Given this list of marker genes TNFSF14, EHD1, EHD2, FLOT1, NFATC2, IL4R, CAPN2, GDF15, CD53, CCL8, CXCL9, ADGRB1, MYOD1, RIPOR2, SCGB3A1 (NCBI Gene Id 92304), MAPK14, here is a description of the gene set: Any process that activates or increases the frequency, rate or extent of myoblast fusion. Human Gene Set: GOBP_POSITIVE_REGULATION_OF_MYOBLAST_FUSION species: Homo sapiens